The following is a description of a gene set: studied in species Homo sapiens Catalysis of the transfer of a pentosyl group from one compound (donor) to another (acceptor). Human Gene Set: GOMF_PENTOSYLTRANSFERASE_ACTIVITY, and this is the list of marker genes: SIRT2, PNP, PARP11, PARP4, PARP6, PRTFDC1, GXYLT2, UPP1, PPAT, TYMP, UPP2, ZC3HAV1 (zinc finger CCCH-type containing, antiviral 1), LACC1, QTRT2, GXYLT1, SIRT6, APRT, PARP10, PARP15, QTRT1, PARP9, SIRT3, ARF4 (ADP ribosylation factor 4), TIPARP, HPRT1, LARGE1, PARP2, POGLUT1, POGLUT2, PARP3, ART3 (ADP-ribosyltransferase 3 (inactive)), TNKS2, UMPS, XYLT2, NAMPT, SIRT1, PARP16, PARP8, SIRT4, SIRT5, ART1, TNKS, MTAP, PARP12, QPRT, XXYLT1, PARP14, POGLUT3, PARP1, RXYLT1, LARGE2, ART4, ART5, XYLT1